The following is a description of a gene set: species: Homo sapiens Human Gene Set: GOBP_AUTOPHAGOSOME_MEMBRANE_DOCKING The initial attachment of an autophagosome membrane to a target membrane, mediated by proteins protruding from the membrane of the vesicle and the target membrane. Docking requires only that the two membranes come close enough for these proteins to interact and adhere., and this is the list of marker genes: VAMP8, ATP2A2, ATG14, STX17, VMP1, CALM1 (NCBI Gene Id 801), SNAP29 (NCBI Gene Id 9342)